The following is a description of a gene set: from publication Chen Y, Wang X (PMID 31504780) Genes predicted to be targets of miRBase v22 microRNA hsa-miR-5009-5p in miRDB v6.0 with MirTarget v4 prediction scores > 80 (high confidence targets). species: Homo sapiens Human Gene Set: MIR5009_5P, and this is the list of marker genes: FGF12, BZW1, FAM227B, ENPEP, PHF21A, BLTP3B, TNFSF11, HACD1, TREM1, SULT1C2, MYT1, SRR, CLTRN, HLF, SPIN1, STXBP5, SOCS5, RAP1B, APIP, ATP2B4, CSRNP2, HACD4, RNF114, HDAC9, PRKAA2, C3orf38, HRH4, FST, STIM1, MTHFD2L, PIK3CG, RAB2B, SNX6, ANTXR1, SNAI2, RNF150, ZNF292, MMUT, DCAF4L2, PLB1, ZFAND1, CLIP4, RALGAPB, TYW5, GPR107, YWHAQ, EN2, RBBP5, TBKBP1, SLC15A2, LRRC2, LHX1, BHLHE41, GNAI2, SNAPC3, IGF2BP3, PALMD, GABRG2, DPP10